Given this list of marker genes SLA, KCNA6, TRIB2, KCTD7 (NCBI Gene Id 154881), SLC17A7, IL1RN, RBFOX2, BCL2L11, CYC1, DYNLT1, TBC1D2B, SELL, RABIF, B3GAT2, BAP1, IL10RA, NDUFA7, STAB1, CLDN8, TPD52L1, EVI2A, ANKRD7, PLCB4, ALB, SLC6A11, BRINP1, IMPG1, NBR1, HLA-DQA1, RHOQ, MBNL2, EPB41L3, CACNA1H, RUNDC3A (NCBI Gene Id 10900), PIK3C2G, CNGA1, SEMG1, SLC22A13, SEMA3C, ERC2-IT1, ST8SIA5, COPG2IT1, LINC00588, POLD1, LRRN3, TGM3, ITGA8, ACP2, CDKL1, DEFA6, C1orf216, ARHGEF9, TBCD, MEOX2, TAF9, GRM8, KLRG1, PTPRE, FCN2, SAR1A, ASMT, STRN, MASP2, TEX30, SIGLEC7, HYAL3, S100A11, EVI2B (ecotropic viral integration site 2B), RNF144A, SLC26A10P, TOM1L1, DCAF11, SNRPB, CALCR, IMMT, ANXA9, SEMG2, TRIM31, SCNN1A, ST6GAL1, RYK, FAM182B, PRNP, PDK4, LIN7A (lin-7 homolog A, crumbs cell polarity complex component), CLCN3, BMP2, RSAD2, MYO1B, INA, HPCA, AKAP11, SMARCC2, CD58, GRIN1, UNC93A, GUCY1A2, SNX7, CNKSR2, ABCD1, CPT1A (NCBI Gene Id 1374), MAP3K14, RAB11A, EPPIN, SHOX, USP2, KCTD12, KIAA1549L, ICAM4, AADAC, POLD3, EIF4G3, ZMYND10, SPINT2, NCOA3, TJP3, ERBB4 (erb-b2 receptor tyrosine kinase 4), PALLD, CD8A, SCGB1A1, APBA3, NDST1, YWHAQ, SUSD6, N4BP2L2-IT2, PLPP1, PCLO (NCBI Gene Id 56630), EZH2, ITGA1 (NCBI Gene Id 3672), MPPED2, DCAF4, ST3GAL4, CDC42BPA, SDHC, OR10H3, P2RY14 (NCBI Gene Id 9934), PCSK5, SLC22A4, EXTL2, SUSD5, DPYSL4, KPNA6, WIPI1, SOCS1, WHAMM, SHOX2, TOP1, GSTP1, ANXA1, S1PR1, KIDINS220, SULF1, ANPEP, SNTB2 (syntrophin beta 2), LILRA1, IFIH1, TMCO1 (transmembrane and coiled-coil domains 1), TRAF6 (NCBI Gene Id 7189), PRR4, PTPRO, ONECUT1, SLC4A7, HK3, TNFAIP6, ETFB, C5, DZIP3, REG1CP, CD8B, CAV2, APCS, HSPA4, GC, PDE6A, REEP5, MID1, GABRE, C9, H4C2, GFI1, GSTT1, TNNI2, PPP1R2C, SLC6A1, NFIL3, CSRP3, IL5RA, DNAH9, KCNS3, CHST10, CCIN, PARN, RIDA, RAD23A (RAD23 homolog A, nucleotide excision repair protein), CXCL5, C1orf105, PDZD2, here is a description of the gene set: studied in species Homo sapiens Human Gene Set: GSE24574_BCL6_HIGH_TFH_VS_TFH_CD4_TCELL_UP from publication Kitano M, Moriyama S, Ando Y, Hikida M, Mori Y, Kurosaki T, Okada T (PMID 21636294) Genes up-regulated in BCL6 high follicular helper T cells (Tfh) versus all Tfh. We found that a number of Tfh cells downmodulated BCL6 protein after their development, and we sought to compare the gene expression between BCL6-hi Tfh cells and BCL6-low Tfh cells.